Given this list of marker genes CRLF2, H3C10, TSLP, IRS1, SMARCA4, PIK3R3, JAK1, H3C11, RAG2, SOCS2, RAG1, H3C2, H3C14 (H3 clustered histone 14), H3C1, BRWD1, IL7R, H3C12, PIK3R2, CISH, SOCS1, H3C13 (H3 clustered histone 13), IRS2, H3C3, JAK3, IL2RG, HGF, PIK3R1, IL7, H3C7, STAT5A, H3C15, STAT3, STAT5B, H3C4, H3C6, H3C8, here is a description of the gene set: Human Gene Set: REACTOME_INTERLEUKIN_7_SIGNALING Interleukin-7 signaling studied in species Homo sapiens